The following is a description of a gene set: The portion of the plasma membrane surrounding a microvillus. species: Mus musculus Mouse Gene Set: GOCC_MICROVILLUS_MEMBRANE, and this is the list of marker genes: Ceacam20, Itgb3, Itgav, Amn1, Prom1, Slc26a2, Slc38a4, Slc7a8, Prom2, Pdzk1, Cubn, Ctnnb1, Muc4, Cdhr5, Cdhr2, Slc6a6, Slc34a2, Dpep1, Nherf1, Mttp, Scarb1 (NCBI Gene Id 52288), Ptprh, Adcy6, Ceacam1, Amn, Podxl (NCBI Gene Id 27205), Ezr, Slc7a11, Cd24a, Slc7a5, Car9, Muc20, Msn, Pdpn (NCBI Gene Id 14726)